The following is a description of a gene set: Human Gene Set: HP_ABNORMAL_CARDIOVASCULAR_SYSTEM_PHYSIOLOGY studied in species Homo sapiens Abnormal cardiovascular system physiology Abnormal functionality of the cardiovascular system., and this is the list of marker genes: PUF60 (poly(U) binding splicing factor 60), TREX1, DNASE1, RYR2, DCAF17, ETS1, PLP1, MYD88, PYGM, RRAGC, SDCCAG8, SREBF1, SLCO2A1, BBS12, ALK, FOXA2, OBSCN, AGK, DEPDC5, COL4A5, SOS2, COPA, RNASEH2B, RHD, PMM2, BNC2, GNB2, SLC25A13, PEX26, COX8A, CTCF, EFEMP2, EP300, HMCN1, IL12B, RBCK1, NR3C1, ABCC9, ABCA12 (ATP binding cassette subfamily A member 12), SLC19A2, MYL2, PRKG2, FBN2, DPP9, SIN3A, HIRA, AMACR, RANGRF, KCNJ10, RASA1, HESX1, STAT1, WNT5A, AGGF1, SMARCA4, SNORD118 (NCBI Gene Id 727676), WFS1, UFD1, BBS9, RS1, SHH, GP1BB, PRG4, AHDC1, DNAJC19, SDHB, NFIX, F5, MYH9, ACTN4, FXN, HABP2 (NCBI Gene Id 3026), ECHS1, LARS2, HNRNPA2B1, CLXN, SCN4A, TSHB, ERCC8, ARFGEF2, GEMIN4, CD2AP, HSD3B7, NFU1, LTBP2, CACNA1A, WNK4, IL12A-AS1, DSC3, KIF20A, B3GALT6, PEX13, KRAS, SGO1, ARVCF, MAN2B1 (NCBI Gene Id 4125), WBP4, DEAF1, KCNJ1, CCM2 (NCBI Gene Id 9225), PEX14, FLNC, PEX1, YY1AP1, RNU7-1, TLL1, H19 (H19, imprinted maternally expressed transcript), COL6A1, DVL1, LHX4, RMRP, MYCN, COL4A3, MAP2K2, AGR2, WNK1, MAT2A, EXT2, RPS6KA3 (ribosomal protein S6 kinase A3), MAX (NCBI Gene Id 4149), ITGA8, ADAMTSL4, KCNQ1, FOXC2, C4A, FKBP14, MYH7, ANK2, LRIG2, MSH6, TGFB2, ENG, KCNE2, ARSK, EGFR (epidermal growth factor receptor), LRRK2 (NCBI Gene Id 399472), AGTR1, INS (insulin), ATP1B1, SLC31A1, ANKRD1, MRPL39, KANSL1, HDAC4, TANGO2, DYRK1B, REN, STK11, NF2, DPAGT1, EMD, SEMA4A, NUMA1, LZTFL1, MYOZ2, MT-ND3, MT-ND6, THSD1, ACTC1, MIF, NOTCH3, COX6B1, TUBB, CYSLTR2, TEK, CCDC22, SOX5, FLAD1, CP, PEX19, MT-TH, TTC7A, NPHP3, IDS, TP53, ZFX, CAV3, GCDH (NCBI Gene Id 2639), MYBPC3, PGAP1, IMPDH2, TKFC, SERPINE1, NEUROG3, KMT2D, GMPPB, MT-TV, RPS19, CACNA1D, C4B, CHST14, RAB3GAP2, CTLA4, SMARCB1, APOB (NCBI Gene Id 338), PRTN3, GJA1, POU2AF1 (NCBI Gene Id 5450), CLCNKB, NOS1AP, EXOSC2, PITX2, PAX8, TTN, SNX10, FKBP6, EBP, TAFAZZIN, F13A1, FOXF1, SPTBN1, PDX1, GP1BA (glycoprotein Ib platelet subunit alpha), GIMAP5, NFKB2, SMC1A, IYD, SDHAF1, TBX5, COL1A2, B3GLCT, RBPJ, F13B, IRF4, EDA2R, TGFB3, AIP, KIF1B, MMP14, LTBP1, RAD21, MTRR, VPS37D, PIK3C2A, SGCD, XK, PMS2, CDC42, SMAD3, POR, WDR37, COQ4, NR3C2, H4C3, ANKS6, CLDN16, DES, RRAGD, FRG1, DNM2, MPI, HLA-DPA1, SCN3B, MAPRE2, LRP6, CLIC2, KIF23, ABCC8, F7, DHCR7, TMTC3, SEMA4D, FIG4, BVES, FSHR, FIP1L1, LMBRD1, UBE2L3, TNFSF15, SCN1B, TPM2, XPNPEP3, MYLK, XYLT2, MYPN, NAF1, GNAI2, RAF1, TMEM260, CRLF1, SP110, USP8, MLH1, MDM2, BBS1, TGIF1, STX1A, ACTG2, ADRA2A, LMO1, CLCN2, BCOR, KCNJ8, VCP, NOTCH2NLC, HPS1, CA2, TRIM28, GALE, NOS3, FGFR2, PLVAP, KCNE3, TXNDC15, UBR1, DLD, PTPN11, ADAR, GNS, KCNJ11 (NCBI Gene Id 3767), HACE1, HADH, PAX2 (paired box 2), PPOX, SH2B3, HSD3B2, WAS, GNAQ (G protein subunit alpha q), RHAG, ARPC4, SOX3, SCNN1B, ACBD6, SFTPC, TAOK1, MTTP, ARPC5, SDHAF2, PTPN22, BUB3, XPNPEP2, CALM3, BRAF, PXK, CLCF1, CORIN, MYL4, TRIM37, INPP5E, MAP3K7, CIC, HJV, HR, THOC2, BBS10, ERCC6, SLC30A10, DNAJC30, GATA6, ZIC3, HSD11B2, CHD3, SMAD4, GPX4, CEP164, BMP2, PKD1, AAAS, SON, HAMP (hepcidin antimicrobial peptide), MT-TF, PSEN1, SCN10A, ACAD8, MT-TS2, ITCH, MMACHC, RHCE, ALG9, IL6ST, PDGFRA, ALB, PRORP, CAP2, DOCK8, AGPAT2, HLA-B, ACTA2, KCNK3, ZNF699, ZFHX3, RNF2, KCNE5, RAP1B, SPRED1, MYC, LCK, PLN, SKIC2 (NCBI Gene Id 6499), GNPTG, SLC1A3, GREM1, GUCY1A1, COX16, KCND3, BMP6, ASL, ALDOB, AVPR2, GDAP1, ADCY5, SAA1, LMAN1 (lectin, mannose binding 1), MTHFR, ARL6, CSF2RB, LMNB1, CDC73, MTO1, TMEM43, PDE3A, COMT, PLCG2, LEP, COLQ, NR4A2, MYH6, MYL3, AFF4, THPO, JAK2, DZIP1, DZIP1L, SHARPIN, MUC1, TNNC2, PIK3CA, TCAP, FMO3, DYSF, TNNI3K, ATP7A, NABP1, CHST3, SAMHD1, GPC3, ALG5, SLC6A5, ZNF365, PLOD1, DLST, ABCG8, TLR7, TSC1, D2HGDH, CYP17A1, TSPYL1, CYP7B1, GATA4, AQP2, SDHC, SMC5, UCP2, HPSE2, ODAD1, TNXB, ATP13A3, DMD, MYZAP, HRAS, ACTB, CCR6, SUGCT, SF3B1, CFTR (CF transmembrane conductance regulator), DSP, RNASEH1, TECRL, LIMS2, COL1A1, DLL4, DIS3L2, PCCA, COX5A, APRT, MTFMT, MT-ATP6, LPL, SYNE2, NPHP1, TNFRSF1A, B2M, FCGR2C, ALPL, AKT3, TBL1XR1, CRYAB, RANBP2, COL3A1, NEDD4L, NPHP4, SNIP1, SCN9A (sodium voltage-gated channel alpha subunit 9), DOHH, MT-TL1, TBX2, TBL2, HSPG2, GMPPA, MAP1B (NCBI Gene Id 4131), CFH, LCAT, ZNF341, WIPF1, DPYSL5, GBE1, SNTA1, AGO2, G6PC1, TNNC1, IDUA, WAC, ZNFX1, TOR1AIP1, ABCG5, ATOH7, MEF2A, CCR1, PRNP, STAT5B, SLC2A10, SLC25A4, AGA, SNCA, MARS2, FGFR3, LEPR, ITGB3, TGFBR2, MYRF, POU6F2, CASR (NCBI Gene Id 846), NODAL, EIF4H, BLK, F2, BAG3, ACY1, MRAS, COL5A1, MGME1, NKX2-6, LDB3, WT1, RAB23, STIL, IKZF1, HTRA1, CNTNAP2, HLA-DRB1, DSG1, BANF1, BMP4, MST1 (macrophage stimulating 1), ATM, CCDC32, CC2D2A, CFB, MAFB, PSAP, SLC37A4, MYSM1, GFM2, LAMA4, SLC5A5 (solute carrier family 5 member 5), TBX19, CUBN, FCGR2B, TERC, GJA5, CYP21A2, THOC6, STIM1, HBA2, CACNA2D1, PEX2, DAW1, SLC4A1, KCTD1, PEX11B, ABCA3 (NCBI Gene Id 21), COL4A4, SZT2, SLC7A7, STN1, NDUFB11, ZBTB16, BRF1, SERPINA6, PIGU, IGHG1, GPD1L, POLD1, SEC61A1, GATA5, PKD2, PTGIS, COL4A2, CHCHD2, TERT, DUOXA2, LIMK1, TAB2, SPG11, MYMX, SPEG, MPL (NCBI Gene Id 4352), CASQ2, ALDOA, PHOX2B, POT1, MT-ND5, TNFAIP3, JPH2, AKAP9, PYROXD1, COQ2, GLUL, FAS, TNNI3, PCCB, KCNJ5, FLNA, PET100, DSG2, MED12, PROS1, SLC12A1, TNPO3, MLXIPL, THBD, CLCNKA, PSEN2, SOS1, NKAP, SPP1, MT-ND4, KYNU (NCBI Gene Id 8942), RFC2, SLC12A3, IL23R, CTNS, UQCRFS1, ATP1A3, DCDC2, CTC1, SCARB2, ABCC6, CRKL, LAMA3, DOCK6, IL12A, NCAPG2, NEU1, SYNE1, RAI1, BMPR2, CITED2, BAZ1B, FGG, ENPP1, APOLD1, PLIN1, MUC5B, NEK1, NDUFB10, SLC29A3, JMJD1C, DUX4, CCND2, GLIS3, CAPNS1, SRY, GET3, ACADVL, LRPPRC, SLC17A5, DCTN1, P2RY11, ELAC2, GGCX, WDPCP, HNRNPK, CFHR1, TRPM4 (NCBI Gene Id 8184), RTL1, TFAM, EYA4, PRKCSH, BICD2, SEC63, IL12RB1, PIGN, CDC45, ATP5MK, BRCC3 (NCBI Gene Id 79184), KCNA5, GTPBP3, SIM1, VANGL1, DUOX2, EFEMP1, DDX6, USP48, SMARCAL1, FOS, SAT1, NAGA, CD46, MVK, CLIP2, CLDN1, CHD7, GATA2, PTCH1, TXNRD2, TMEM126B, COG7, TTPA, VPS33A, RNU4ATAC, PRDM5, VPS35L, PPCS, BICC1, SPARC, CPT1A, MYLK2, BSCL2, PRKACA, STING1, BEST1, STAG2, RTEL1, MYO1H, RACGAP1, YY1, HEXB, TWNK, FARSB, FNIP1, ATP5F1A, RARA, MKKS, TNFSF11, KCNH2 (NCBI Gene Id 4027), ZNF469, ELP1, C1QBP, RB1, TF, LMNA, RBM10, PLCH1, FBP1, KRIT1, MKS1, SLC6A6, DEF6, STAT3, BCR, CUL3, BMPR1A, CTNNA3, DDX3X, SMAD6, HPGD, TMEM237, LPIN1, SMARCE1, SYT2, WIPI2, NDUFA2, MT-ND2, ABCD4, GJA8, TDP2, DBH, ATRX, NSMCE2, CFHR3, TPM1, SVIL, ADD1, COG1, HBA1, CACNB2, CNBP, SARS2, ZEB2, MECP2, KCNE1, LZTR1, CYB561, POLG2, F8 (NCBI Gene Id 14069), COQ7, KCNH1, CCDC28B, ARHGAP31, NPM1, PRKG1, PDSS1, IFNG, SGCG, ADK, EPHB2, TNNT2, MEFV, INF2, MTX2, ARSA, SCN5A, KAT6A, AGXT, EHMT1, CTNNB1, GANAB, RNF213, CCNQ, SCAPER, F10, FKTN, GTF2I, SLC6A8, EIF4G1, NOTCH1, TGFBR3, GBA1, HADHA, BAG5, RNF135, FHL2, SLC40A1, MYMK, ABCA1, SLC25A24, SCUBE3, SALL4 (spalt like transcription factor 4), NDUFAF6, CSGALNACT1, PBX1, ERAP1, EPHB4, TRIP13, CLCN1, GNA11, NRXN1, BBS5, LIPT1, SLC25A3, ACADM (NCBI Gene Id 51779), PHF21A, MBTPS2, NDUFA8, GPR101, FBN1, FGF8, COLGALT1, FN1, TOR1A, ACTG1, CLPB, PIGM, MYO5B, GTF2IRD2, TPI1, TGFBR1, KLHL24, DNAJB11, PDE11A, KRT18, MT-TC, VCL, SCNN1A, HNF4A, IFT27, NKX2-5, EPOR, CRELD1, EPCAM (epithelial cell adhesion molecule), RRAS2, PLXND1, HAAO, UBAC2, HLA-DPB1, NEK9, CALR, SOX9, P4HA2, CEP290, PRDX1, CDKN2C, ATXN7, HAND2, DGUOK, POLG, PRIM1, IFT74, LDLRAP1, C12orf57, FOXP1, LOX, FHOD3, DST, CYP11B2, AGT, IFT172, HGD, LHX3, TCIRG1, NFIA, FLI1, SLC4A3, ZNRF3, VWF, IRF2BP2, PLD1, KCNJ2, RPL3L, KDM6A, BRCA2, CAVIN1, LIPA, TRPC6, PNPLA2, SLC35A2, IPO8 (NCBI Gene Id 10526), MFAP5, AP1S3, SFTPA1, SCO1, NKX2-1, ATP6AP1, TRAF3IP1, TTC8, DSE, GDF2, ROR2, PEX5, PRKAR1A, MYH11, NPPA, SMO, IL6, CACNA1C, PGM1, KIFBP, SPIB, SIX3, CASP10, CCN2, GNPTAB, ACAT1, KCNJ18, TRDN, STOX1, TAF2, HNRNPA1, ARPC1B, SHPK (sedoheptulokinase), OTUD5, LIPC, RIGI, ATPAF2, GIGYF2, DLK1, SCN4B, ADA2, PPARG, WDR19, RGS5, COA6, HBB, DUX4L1, ARMC5, ATP6V1A, COL5A2, TNIP1, BCHE, FOXH1, UBE2A, APOE, AMN, TLR4 (toll like receptor 4), CDKN2B, NIPBL, FGB, PEX10, IQCB1, MEN1, PCSK9, LMX1B, HCRT, TBX4, BBIP1, FZD4, RNU12, CISD2, CHEK2, TG, CSF2RA (NCBI Gene Id 8282), IL36RN, CYP27A1, CELA2A, BBS7, SDHD, ATP6V0A2, C3, NEXN, CEP19, SKIC3, CYP11A1, NNT, FGA, BICRA, MMEL1, MGP, NOD2, NAA10, SPECC1L, GFI1B, CBL, CRIPTO, ACVRL1, CALM2, TRRAP, TMEM67, SFTPB (NCBI Gene Id 6439), PSMB8, PPA2, DOLK, SLC30A9, NR2F2, AEBP1 (NCBI Gene Id 165), NDUFS2, BPTF, EXOSC5 (exosome component 5), POMT1, DLL1, CDKN2A, JUP (junction plakoglobin), WNT4, NCF1 (neutrophil cytosolic factor 1), CDON, SCNN1G (sodium channel epithelial 1 subunit gamma), TBCK, SOX10, SERPINF2, CIZ1, TAF1A, WASHC5, CHRNA3, TBX1, LRP1, PDE4D, CEP83, MT-TQ, PTEN, CYP3A5, DPH1, MC4R, CACNA1H, SPRED2, STAT2, CD55, CWC27, NDUFAF1, EIF2AK4, PLAAT3, LRP4, TMEM70, POMT2, GRIN1 (glutamate ionotropic receptor NMDA type subunit 1), PDCD10, IFT140, BUB1B, NT5E, LIPE, SCO2, HADHB, TSHR, RPL5, CFI, ANKRD11, WRN, FLT1 (fms related receptor tyrosine kinase 1), MRAP, MC2R, FGD1, LAMC2, RRAS, MPV17, FMR1, TCF4, SDHA, DNAJC13, DHPS, MT-CO1, XYLT1, FBXW11, CCND1, NTRK1, MRPS14, BAP1, SAMD9, ANGPTL6, CR2, ARF1, IGFBP7, LRP5, KLRC4, DBR1, NF1, MGAT2, DNMT3B, SELENON, CDKN1B, DPH2, MT-CO2, STRA6, ALPK3, HCN4, PMS1, SEC24C, EOGT, BTNL2, THSD4, ROBO4, PAM16, DNMT3A, LIFR, MT-ATP8, LEMD2, PIK3R2, TBX3, ITGA2, MUTYH, GLYCTK, NUP155, GABRA3, LDLR, PSMD12, MRPL12, PEX16, IQSEC2, SBDS, FAH, CTSH, PHYH, GSN, FBXL4, SCLT1, TRIP4, NDP, FLT4, GNB5, PLEC, CPT2 (carnitine palmitoyltransferase 2), DDC, PML, PARN, CAV1, PLAU, ALMS1, TTR, ACE, FH, FCGR3B, DNAL1, MCTP2, ISCU, GPR35, ATP11A, SMAD9, LAMB2, OSGEP, TULP3, IKBKG, MMUT (NCBI Gene Id 4594), ATP6V1E1, PRF1, HEY2, CALM1, SLMAP, TJP2, F9, DYRK1A, VEZF1, ESAM, TOP3A, TPM3, HEATR3, DMPK, ZNF408, MAPK1, FKRP, HMBS, GAA (alpha glucosidase), CIROP, ERCC4, ITPR1, RNF168, ZMPSTE24, KDM1A, LTBP3, KIT, PKP2, SKI, RNF125, TNFRSF11B, DVL3, CEP57, LYZ, HIVEP2, GP9, AARS2, MAP2K1, RNASEH2C, DCHS1, ALX4, IFNGR1, ABCD3, RPGRIP1L, GLA, PRDM16, LEMD3, SLC25A20, HFE, RBM20, ADAMTSL2, ANO1, HEPHL1, SUFU, ECE1, KIAA0319L, THRB, CYP26C1, ZFYVE19, STX16, SMAD2, LAMB3, ATP1A2, VAC14, HLA-DQB1, COL4A1 (collagen type IV alpha 1 chain), GYG1, ALG10B, STX3, STAT4, SLC25A11, PEX12 (peroxisomal biogenesis factor 12), DISP1, MT-TK, PKHD1, IRAK1, HMGCL, APP, PPP1R13L, MOG, CD109, FUZ, FAM13A, BUD23, GTF2IRD1, MED25, MEGF8, EPAS1, UMOD, TRAPPC11, EPG5, DSC2, HCCS, BANK1, DOCK7, LACC1, SMCHD1, USP18, ZNF148, TNFRSF11A, PEX3, LRP12, ITGA2B, RSPRY1, RRM2B, RBBP8, ACTN2, APOA1, GCK, GAS1, TRIM32, CBS, INVS, NONO, TINF2, AKT1, AMER1, GNAS, SRSF2, OFD1, GPC4, COX7B, FOCAD, STRADA, GDF1, IL10, RHBDF2, STT3A, MCFD2, LBR, ARSB, SMC3 (NCBI Gene Id 9126), SGCA, SARDH, TBX20, PIEZO1, MDH2, CLCN7, ACP5, WDR35, SPRY2, CDH2, RPS20, HMOX1, HELLPAR, BBS4, POLE, IFT56, FHL1, VPS35, TET2, ABCB4, IFIH1, FBLN5, ADA, OTX2, IRX5, POU3F4, NAXD, ADAMTS10, GLI2, TMPO, PROP1, ERMARD, F11, JAZF1, MADD, STX5, SFTPA2 (surfactant protein A2), POU1F1, ERI1, B4GALT7 (NCBI Gene Id 202179), KCNJ3, LIN28B, COQ9, PPP1CB (NCBI Gene Id 5500), ACTA1 (NCBI Gene Id 58), IVD, CAPN5, BSND, MEG3, SLC25A26, ADNP, KIF12, MT-ND1, GCH1, CSRP3, KCNN4, ATP5F1E (ATP synthase F1 subunit epsilon), PLOD3, SERPING1, EDA, ALDH18A1, CYP11B1, ABCB6, FGFR1, PCGF2, ADAMTS17, LAMA2, LMOD2, CREBBP, PRKAG2, RYR1, ITGAM, DTNA, JAG2, SLC35A1, BBS2, NEK8, FLII, NDE1, SNAP29 (NCBI Gene Id 9342), NOTCH2 (notch receptor 2), ADAMTS19, SHOC2, BRAT1, LAMP2, ALDH1A2, MT-TW, PDCD1, ADAMTS13, CST3, SERPINC1, PEX7, ATP5F1D, SLC34A2, GALC, TWIST1, NRAS, STAR (steroidogenic acute regulatory protein), RUNX1, ACAD9, ZIC2, MT-CO3, ELN, LBX1, SEMA3A, TNFSF4, G6PC3, POLR3A, CRLS1, GLB1, MLX (MAX dimerization protein MLX), CACNA1S, RET, APC, GNB3, CHD6, RASA2, CIDEC, MT-CYB, GATAD1, TMEM127, DPP6, TMEM270, HTRA2, METTL27, PDGFB, MMP2, TRAF7, CFAP418, TSPAN12, KLHL3, TSC2, PSMB9, FAT4, LSM11, FOXE3, PROC, PEX6, HMGCR, NAGS, IL10RA, IRF5 (NCBI Gene Id 84729), GCGR, CPOX, HNF1A, NLRC4 (NCBI Gene Id 58484), CDH23, MSH2, SCN2B, RNASEH2A, RREB1, REST, MT-ND4L, SLC22A5, RPL27, ASXL1, RIT1, CDKN1A, VHL, PIGA, TPO, BUB1 (NCBI Gene Id 699)